The following is a description of a gene set: Human Gene Set: MIR122B_3P Genes predicted to be targets of miRBase v22 microRNA hsa-miR-122b-3p in miRDB v6.0 with MirTarget v4 prediction scores > 80 (high confidence targets). studied in species Homo sapiens from publication Chen Y, Wang X (PMID 31504780), and this is the list of marker genes: CPEB2, MYCL, RDX, PDCD10, TMEM242 (transmembrane protein 242), BTBD7, YWHAG, DDX4, COBL, USP51, RRAGB, COL19A1, TMA16, TSC22D2, ZC3H12C, FYTTD1, ZNF800, GRM5, CDK17, SMAD7, TMEM164, SS18L1, ING3, UBA3, KIRREL3, RPS6KA6, ELL2, SAMD8, SEH1L, ZFP42, RPS10-NUDT3, TMLHE, UBE4B, GPM6A, POLR2M, TRIO, HS2ST1, NUDT3, ZZZ3, PPP1R2, SRSF2, LAMP1, PABIR2, PSEN1 (presenilin 1), OR10W1, CANX, DNAJB4, UMAD1, CTDSPL, PPP1CC, PHC3, RIPK1 (NCBI Gene Id 8737), HERC3, TOGARAM1, STK38L, PARD3B, WDR82, PHYHIPL, PEG3, PDE4B, PCLAF, CLCN4, DCUN1D4, ANOS1, RINT1, USP4, FOXR2, ZIC5, RIPOR3, DHRSX, SMARCE1, STAU2, OARD1, STMN4, ALCAM, MAP2K4, TFG, LOX, PPP1R1A, CHIC2, NFYB, CCL28, AKAP11, MSANTD3-TMEFF1, SERINC5, TANGO2, GAD2, FAM117A, RAD54B, PWWP3B, PLA2G12B, CYP3A5, MAP3K1 (NCBI Gene Id 4214), SLC35B3, ZNF326, C9orf72, SNRK, GRIA2, FOXO3, AGTR1, APPL1, FAM83H, PCDH19, PRKG1, ZNF704, MAGEB18, WDR33, AAK1, GPR161, SP1, CDK8, FSBP, CDK14, TIAM1, TMEM94, MMD, HSD17B11, BCL2L11, C2CD3, TMEM43, FXR1, NAP1L5, NAV3, RUNX1T1, CAMSAP2, TAP1, RTN3, SRCIN1, TOPORS, RC3H1, GCOM1, ATP1B1, UBN1, UCHL5, HOXC9, MLX, PDIA4, TMEFF1, CDADC1, CCDC85A, MBNL3, WTAP